The following is a description of a gene set: species: Homo sapiens Human Gene Set: GOCC_PAR_POLARITY_COMPLEX A protein kinase complex that is required for the establishment of a cell polarity axis during the cell division cycle. Binds directly to activated CDC42 GTPase and is required for orchestrating a cellular gradient of CDC42. In S. cerevisiae components are: BEM1, CDC24 and CLA4; from worms to vertebrates it contains a PAR6 protein, PAR3 protein and an atypical PKC., and this is the list of marker genes: PRKCZ, PARD6G, PARD6A, PARD3, PRKCI, PARD6B